The following is a description of a gene set: studied in species Homo sapiens The activity of binding selectively and non-covalently to and distorting the original structure of DNA, typically a straight helix, into a bend, or increasing the bend if the original structure was intrinsically bent due to its sequence. Human Gene Set: GOMF_DNA_BINDING_BENDING, and this is the list of marker genes: TREX1, HMGB1, HMGB4, LEF1, FOXD1, FOXI1, TOP2A, TERF1, HHEX, HMGA2, FOXD4, FOXL1, HMGA1, HMGB3, SAP30L, TOP1, HMGB2, FOXC1, TFAM